The following is a description of a gene set: The chemical reactions and pathways resulting in the formation of carbohydrate derivative. Human Gene Set: GOBP_CARBOHYDRATE_DERIVATIVE_BIOSYNTHETIC_PROCESS studied in species Homo sapiens, and this is the list of marker genes: NDUFS7, PIGC, RRM1, B3GNT4, AGO2, PGM2, RRM2, ALG2, CTNNB1, FA2H, AK9, MIR298, DOLK, PMM2, CYTL1, B3GALT9, ADSS2, GCNT3, NDUFS6, GMPPB, TRAK1, B3GLCT (NCBI Gene Id 145173), UGP2, POGLUT3, AQP11, NANP, NDUFA1, HAS1, AK2, NFKB1, CCR7, GALNT16, SDHB, CHST12, ADCY8, IMPDH1, MT-ATP8, NPPC, GALNT1, EGF, XYLB, UCK1, NME2, CHST7 (NCBI Gene Id 56548), SLC39A8, DHDDS, ATP5MC2, MT-ND2, ST3GAL3, CWH43, SMPD3, GALNT12, B4GALNT2, AK5, TMEM165, CHP1, CDA, NDUFA9, PCK1, MT-ND5, ALG8, NDUFB11, CHST8, EXT2, NDUFS4, MGAT3 (NCBI Gene Id 4248), FUT2, EXTL3, GNPDA2, MIR106A (NCBI Gene Id 406899), B3GALT4, PIGN, GK, AK4, ST6GAL2, ATP5PF, DPM1 (dolichyl-phosphate mannosyltransferase subunit 1, catalytic), TKT, PIGV, CHSY1, FUT11, MGAT4D, UQCC3, NME4, CHST2, B3GNT8, ST3GAL6, PRKAA1, CAD, XXYLT1, COG3, POGLUT1, PAPSS2, MGAT4A, PIGZ, PRPSAP2, NPR2, AP2A1, AK1, TCF7L2, PGAP1, AATF, ST8SIA4, GUCY2C, UGDH (UDP-glucose 6-dehydrogenase), ATP5F1C, GALNT6, B3GNT9, HAS3, DDOST, HS3ST1, CERK, ATP5PB, ATIC, ITM2B, B4GALT4, UGCG, POMGNT1, DPM3, NDUFA10, GNPNAT1, PRPS2, POFUT1, RPN1, EXTL1, SCCPDH, PLOD1, B3GNT5, TRAK2, ANTKMT, TMTC1, GALNTL6, B3GNT3, PRPSAP1, MAPDA, B3GALT5, PRKN, ATP5IF1, ABCC5, CEMIP, SLC30A5, UGGT2, B3GALT2, PFAS, TRIP11, ATP5F1D, NANS, GFPT2, NME7, CCL21, GALNT8, ALG10B, POMT1, DOLPP1, FUT3, MT-ND4L, GLCE, TK2, ITM2A, GOLPH3, PIGB, GATA1, FAM3A, MGAT5B, TYW3, CHST13, ALG3, ST3GAL1, OSTC, ATP6V0C, CCDC134, SRD5A3, SOAT1, ATP5MGL, ABO, NUDT2, MIR101-1, DUT, MAN1C1, OST4, FAM20B, TYW5, NME6, ATP5ME, ADCY5, GBGT1, NME1, G6PD, ADCY10, CHST10, PGM3, MPPE1, ADCY1, SLC51B, PIGS, BCL2, ARFGEF1, PINK1, UGGT1, NDST1, MIR153-1, AK3, TPI1, DERL3, GCNT2, ABCA2, OGA, GK2, EOGT, NDST4, VCP (valosin containing protein), NCSTN, RRM2B, LMF1, MAN1A1, SLC35A1, TMTC2, NECAB1, MPI, PIGO, NDUFB9, SLC35C1, GPAA1, MGAT5, GK5, PRPS1L1, TK1, MTAP, LARGE2, ALG12 (ALG12 alpha-1,6-mannosyltransferase), PMM1, B4GALT6, FUT1, RXYLT1, NDUFB1, CTPS2, FUOM, ATP5MK, SDHD, CRPPA, DHFR2, ACOT8, ADCY9, MIR520C, ALDOA, ST6GAL1, HS3ST3A1, ABCA7, CCL19, NDUFA13, GFPT1, SDHA, DGUOK, NDUFA8, DNPH1, STOML2, TGFB1, GXYLT2, NECAB3, NDUFC2, IL4, PAWR, GNPDA1, CHST14, LCMT2, CMAS, DPY19L1, GART, ST6GALNAC6 (ST6 N-acetylgalactosaminide alpha-2,6-sialyltransferase 6), CHST5, MAGT1, TUSC3, MIR675, PIGF, ATP5MF, GALNT18, PIGG, ADCY6, PIGA, DPY19L3, PID1, MGAT4B, MAP2K1, FUT6, NDUFA12, TREM2, ALG1, CHPF2, GALNT14, COLGALT1, ATP5F1EP2, ADCY7, PRKAG2, VANGL2, GALNT9, SLC35B2, CHST6, PPAT, ATP5PD, B3GNT6, NDUFA7, OGT, IL1B, PAICS, IGF1, MAN1A2, LDHC, MAN2A1, ATP5F1A, NDUFS1, NDUFB7, GALNT10, MIR31, B4GALT2, SDHC, GMPS, ADCY2, MT-ND3, SLC2A10, GXYLT1, MIR644A, HS3ST3B1, COX11, ITM2C, UPP2, CLTC, PGAP3, FPGT, ALG9, RFT1, FCSK, SLC25A10, MGAT2, RPN2, ST3GAL4, PPARA, NDUFB2, PSEN1, DCK, CMPK2, C1GALT1C1, ST8SIA6, DSE, VEGFB, LETMD1, PIGW, ATP5MJ, UBE2J1, ENO1, NUS1, ALG11, GNE, UAP1L1, NDUFB10, MT-ND6, ADSL, GALNT15, MIR147A, TM9SF2, SLC25A13, POMT2, PLCB1, GALNT4, VPS9D1, JAK3, DCXR, B3GAT3, NDUFA3, DPM2, PXYLP1, GALNTL5, SLC35C2, GALNT17, SPHK2, ALG5, PIGY, TMEM106A, FUT9, B4GALT5, NDUFS2, TMTC3, DHODH, TMTC4, POFUT2, POMK, BMPR2, POMGNT2, GUCY1A1 (NCBI Gene Id 2982), BACE2, ENTPD5, B3GAT1, ST8SIA1, GMDS, PGAP2, CSGALNACT1, ADCY4, DTYMK, STT3B, B4GALT1, STT3A, FREY1, CTPS1, NDUFB8, B4GALT7, LIPA, NPPA, PIGL, NDUFB5, TRMT12, HS6ST3, MPDU1, SLC2A4, B4GAT1, TYW1B, NAGPA (NCBI Gene Id 51172), NDUFA11, GORASP1, MT-ND1, CHPF, NDUFV3, EDEM3, ST6GALNAC2, DMAC2L, ST3GAL2, PGAP4, A4GALT, APRT, B4GALNT1, IL33, ATP5MC3, B3GNT7, AMPD1, HS3ST6, CHST9, COG7, ALG6, ST6GALNAC4, GOLGA2 (golgin A2), CHST4, UCK2, GUCY2D, ST6GALNAC1, UST, ATP7A, MT-ATP6, B3GALNT2, PLOD2, PRTFDC1, UXS1, AKR1A1, EXTL2, NUDT14, PIGP, FUT8, GAL3ST1, ST6GALNAC3, POGLUT2, NPR1, ALG1L2 (NCBI Gene Id 644974), MGAT1, CHST1, B3GAT2, PRPS1, FUT4, B3GALNT1, MAN2A2, CHST3, NDST3, PDGFB, TMSB4X, MUSTN1, ATP5MG, GMPPA, RAMP1, HK1, ST8SIA2, ATP5MC1, FKRP, PIGH, GALNT5, C20orf173, AMPD3, PAPSS1, CANT1, GALNT11, GFUS, B3GALT1, NDUFA5, MIR20A, DCTD, CHSY3, B4GALT3 (beta-1,4-galactosyltransferase 3), NT5E, GCNT4, TAFAZZIN, DNAJC30, B3GALT6, FUT5, ATP5F1B (NCBI Gene Id 506), MIR323A, A3GALT2, TMEM260, ADK, MAN1B1, NDUFB6, NPPB, NDUFA6, NDUFS8, HS3ST5, FOXL1, PIGU, ADA, HEXA, IMPDH2, TNIP1, ALG10, ADCY3, PIGQ, GAL3ST2, GALNT13, TET3, NDUFS3, ACER2, HAS2, MTHFD1, NDUFB4 (NCBI Gene Id 727762), CSGALNACT2, NDUFC1, GALNT3, DAD1 (NCBI Gene Id 1603), ST8SIA3, NDUFS5, HS6ST1, ADA2, AMDHD2 (NCBI Gene Id 51005), SLC10A7, GAL3ST4 (NCBI Gene Id 94697), GUK1, ALG14, HS3ST4, NDUFV2, UAP1 (NCBI Gene Id 6675), UGT8, UCKL1 (uridine-cytidine kinase 1 like 1), ATP5F1E, CHST11 (carbohydrate sulfotransferase 11), UPP1, NME9 (NME/NM23 family member 9), FKTN, NDUFV1, MIR455, C1GALT1, CMPK1, ALG13, ST6GALNAC5, MGAT4C, GCNT7, SERP1, NME3, GALNT2, GALNT7, HS6ST2 (heparan sulfate 6-O-sulfotransferase 2), UMPS, B3GNT2, MOGS, NDST2, ST8SIA5, ATPSCKMT, NECAB2, ADSS1, TET1, SHMT1, LARGE1, PIGX, MT-ND4, PARP1 (poly(ADP-ribose) polymerase 1), BMPR1B, XYLT2, STAT3, NDUFAB1, SLC35D2, PIGM, PIGT, ANGPT1, HS3ST2, MIR17, TMEM59, TET2, HS2ST1, GUCY2F, FUT7, ST3GAL5, CRYL1, UPRT, TYMS, QNG1, SORD, NME5, AMPD2, HPRT1, KRTCAP2, ATP5PO, TBPL1, EXT1, GCNT1, A4GNT, DPAGT1, FUT10 (NCBI Gene Id 84750), TMEM258, XYLT1, GAL3ST3, GUCY1A2, PNP, GUCY1B1, NME2P1, RFK, PLOD3, PIGK, TYW1, NDUFA2, NDUFB3, MIR144, NAGK, NPC1